The following is a description of a gene set: Panhypogammaglobulinemia A reduction in the circulating levels of all the major classes of immunoglobulin. is characterized by profound decreases in all classes of immunoglobulin with an absence of circulating B lymphocytes. studied in species Homo sapiens Human Gene Set: HP_PANHYPOGAMMAGLOBULINEMIA, and this is the list of marker genes: SKIC3, IGHM, ZAP70, RFXANK, MPLKIP, RAG1, CIITA, JAK3, SP110, ERCC2 (NCBI Gene Id 7269), GTF2H5 (general transcription factor IIH subunit 5), CARS1, ERCC3, TARS1, BTK, DCLRE1C, RFXAP, IL21R, RNF113A, GTF2E2, RAG2, RFX5, PIK3R1 (NCBI Gene Id 5295), AARS1 (alanyl-tRNA synthetase 1), SKIC2